Given this list of marker genes CD19, SP110, RASGRP1, ICOSLG, KMT2D, IRF1, ICOS, PRKCD, PIK3CD, PLCG2, PIK3R1, LRBA, ARHGEF1, KDM6A, LCP2, POLD3, CTNNBL1, IL6R, ELF4, POMP (NCBI Gene Id 51371), FNIP1, BACH2, TOM1, IKBKB, REL, SOCS1, IL21, SEC61A1, CTPS1, TET2, MAP3K14, IRF2BP2, HYOU1, here is a description of the gene set: species: Homo sapiens Abnormal increase or decrease of any B cell subpopulation, measured as percentage of total CD19+ or CD20+ B cells in the blood, compared to a reference range for a given sex and age-group. Human Gene Set: HP_ABNORMAL_B_CELL_SUBSET_DISTRIBUTION Abnormal B cell subset distribution